The following is a description of a gene set: Pathway Definition from KEGG: SMO* -> (SUFU+KIF7) // GLI => (BMP2/4,HHIP,GLI1,PTCH,WNT) Mutation-activated SMO to Hedgehog signaling pathway. Pathway ID: N00017. Pathway type: Variant. Pathway class: nt06269 Basal cell carcinoma. Human Gene Set: KEGG_MEDICUS_VARIANT_MUTATION_ACTIVATED_SMO_TO_HEDGEHOG_SIGNALING_PATHWAY species: Homo sapiens, and this is the list of marker genes: WNT2B, WNT4, WNT8A, WNT3, WNT10A, GLI2, WNT3A, GLI3, PTCH2, WNT6, KIF7, PTCH1, HHIP, WNT5A, WNT8B, GLI1, BMP2, WNT9A, WNT10B, WNT9B, SUFU, WNT1, WNT5B, BMP4, WNT7A, WNT2, WNT7B, SMO, WNT16